The following is a description of a gene set: Human Gene Set: KEGG_MEDICUS_REFERENCE_CROSSTALK_BETWEEN_EXTRINSIC_AND_INTRINSIC_APOPTOTIC_PATHWAYS studied in species Homo sapiens Pathway Definition from KEGG: (FASLG,TNFSF10) -> (FAS,TNFRSF10B) -> FADD -> (CASP8,CASP10) -> BID -> (BAX,BAK1) -> CYCS == APAF1 -> CASP9 -> (CASP3,CASP7) Crosstalk between extrinsic and intrinsic apoptotic pathways. Pathway ID: N00146. Pathway type: Reference. Pathway class: nt06524 Apoptosis., and this is the list of marker genes: BAX, TNFSF10 (NCBI Gene Id 8743), BAK1, CASP9, FAS, CYCS, BID, TNFRSF10B, CASP10, FASLG, APAF1, CASP7 (caspase 7), FADD, CASP3, CASP8